Given this list of marker genes CCDC81, ZC3H7B, TSR1, ALMS1, LMO4, SPN, DCLRE1C, TCAF1, PRR11, ATP8B1, DUOX1, ZNF611, ZNF160 (NCBI Gene Id 90338), GTF2H3, here is a description of the gene set: from publication Spira A, Beane JE, Shah V, Steiling K, Liu G, Schembri F, Gilman S, Dumas YM, Calner P, Sebastiani P, Sridhar S, Beamis J, Lamb C, Anderson T, Gerry N, Keane J, Lenburg ME, Brody JS (PMID 17334370) Down-regulated genes that distinguished smokers with and without lung cancer. studied in species Homo sapiens Human Gene Set: SPIRA_SMOKERS_LUNG_CANCER_DN Lung cancer is the leading cause of death from cancer in the US and the world. The high mortality rate (80-85% within 5 years) results, in part, from a lack of effective tools to diagnose the disease at an early stage. Given that cigarette smoke creates a field of injury throughout the airway, we sought to determine if gene expression in histologically normal large-airway epithelial cells obtained at bronchoscopy from smokers with suspicion of lung cancer could be used as a lung cancer biomarker. Using a training set (n = 77) and gene-expression profiles from Affymetrix HG-U133A microarrays, we identified an 80-gene biomarker that distinguishes smokers with and without lung cancer. We tested the biomarker on an independent test set (n = 52), with an accuracy of 83% (80% sensitive, 84% specific), and on an additional validation set independently obtained from five medical centers (n = 35). Our biomarker had approximately 90% sensitivity for stage 1 cancer across all subjects. Combining cytopathology of lower airway cells obtained at bronchoscopy with the biomarker yielded 95% sensitivity and a 95% negative predictive value. These findings indicate that gene expression in cytologically normal large-airway epithelial cells can serve as a lung cancer biomarker, potentially owing to a cancer-specific airway-wide response to cigarette smoke.